Given this list of marker genes Notch1, Vdr, Cdkn2a, Tnfrsf1b, Pml, Bax, Tnfrsf1a, here is a description of the gene set: studied in species Mus musculus Any process that activates or increases the frequency, rate or extent of apoptotic process involved in development. Mouse Gene Set: GOBP_POSITIVE_REGULATION_OF_APOPTOTIC_PROCESS_INVOLVED_IN_DEVELOPMENT